The following is a description of a gene set: Any process involved in the maintenance of internal levels of plasma lipoprotein particles within an organism. Human Gene Set: GOBP_REGULATION_OF_PLASMA_LIPOPROTEIN_PARTICLE_LEVELS studied in species Homo sapiens, and this is the list of marker genes: APOC2, APOB, PCSK5, APOH, LDLRAP1, PNLIPRP3, NCEH1, APOC1, ADIPOQ, CNPY2, MIR19B1, SCARB1, CETP, MIR199A1, PLA2G7, MIR27B, MIR302A (microRNA 302a), ANGPTL3, MSR1, MIR185, EHD1, PNLIP, APOM, PRKACA, SOAT1, LIPC, MIR148A, ABCG1, APOA2, IL19 (interleukin 19), APOA5, MIR133A1, LMF1, MTTP, FGF21, PON1, LPCAT3, NR1H2, ABCC8 (NCBI Gene Id 6833), NR1H4, ABCA5, PLA2G2E, LPL, PCSK6, PLAGL2, APOA1, TREM2, MIR33A, PRKACG, CES3, PLA2G2A (phospholipase A2 group IIA), MIR379, COMMD1, APOC3, MIR27A (NCBI Gene Id 407018), AGTR1, CSK (NCBI Gene Id 1445), ACSL3, CIDEB, SOAT2, PLA2G10, AGT, DGAT2, PLA2G3, PLTP, PLA2G5 (NCBI Gene Id 5322), MPO, PNLIPRP1, MYLIP, ITGB3, LIPA, ABCA1, APOA4 (NCBI Gene Id 337), GPIHBP1, MIR223, APOE, GPLD1 (NCBI Gene Id 2822), LCAT, FECH, ZDHHC8 (NCBI Gene Id 29801), MIR144, MFSD2A, FURIN, MIR128-1, MIR17, HNRNPK, MIR96, DGAT1 (diacylglycerol O-acyltransferase 1), LIPG, ABCA7, ANXA2, VLDLR, PRKACB, LRPAP1, HMOX1, KHSRP, LDLR, CD36, PNLIPRP2, MIR33B, ANGPTL4, PCSK9, ITGAV